Given this list of marker genes MPI (NCBI Gene Id 4351), here is a description of the gene set: part of: Diseases associated with glycosylation precursor biosynthesis Mannose 6-phosphate isomerase (MPI) normally isomerises fructose 6-phosphate (Fru6P) to mannose 6-phosphate (Man6P) in the cytosol. Man6P is a precursor in the synthesis of GDP-mannose and dolichol-phosphate-mannose, required for mannosyl transfer reactions in the N-glycosylation of proteins. Defects in MPI cause congenital disorder of glycosylation 1b (MPI-CDG, previously known as CDG1b,; MIM:602579), a multisystem disorder characterised by under-glycosylated serum glycoproteins. Unlike PMM2-CDG (CDG1a), there is no neurological involvement with MPI-CDG. Instead, patients present predominantly with diarrhoea, failure to thrive and protein-losing enteropathy. MPI-CDG is one of two CDGs that can be treated with oral mannose supplementation, but can be fatal if left untreated (Marquardt & Denecke 2003). Reactome Pathway: Defective MPI causes MPI-CDG species: Homo sapiens